Given this list of marker genes POLD3, ADA, KMT2D, FOXN1, TBX2, DCLRE1C, here is a description of the gene set: Absence of the thymus. This feature may be appreciated by the lack of a thymic shadow upon radiographic examination. Aplasia of the thymus Human Gene Set: HP_APLASIA_OF_THE_THYMUS species: Homo sapiens